Given this list of marker genes BMPR2, GMPPB, CBFA2T3, APP, DHDDS, IHH, ENPP7 (NCBI Gene Id 339221), NME5, AMDHD2, NDUFA3, PTGDR, PIGT, FIGNL1, ATP5PO, HS3ST1, ALG11, AICDA, NDUFC1 (NADH:ubiquinone oxidoreductase subunit C1), EDEM1, ABCC9, MAN2A2, GM2A, ATP5MC3, SYVN1, GAL3ST3, CHPF, MGAT5 (alpha-1,6-mannosylglycoprotein 6-beta-N-acetylglucosaminyltransferase), RRM2B, CERK, C1GALT1, SLC39A8, ENTPD4, MAGT1, NDUFA9, B3GALT9, ALG14, FAM3A, DUT, PTHLH, ATP5F1B, MT-ND1, GALNT4 (NCBI Gene Id 8693), B4GALT1, PGM1, GIMAP7, G6PD, NEIL1, B4GALT7, SMPD1, NECAB3 (N-terminal EF-hand calcium binding protein 3), AKR1A1, HK3, AMPD3 (NCBI Gene Id 272), MIR195, FAM20B (NCBI Gene Id 9917), M6PR, POGLUT2, TMEM260, SLC2A6, ADCY8, RPIA, GPAA1, SULT1A3, TK1, HGSNAT, P2RX7, GK5, MAP2K1, PMM1, LDHC, PRPSAP2, NAGA, RPN1, GCKR, LARGE1, ATP5F1E, PIGN, CTNNB1, UPRT, SLC35C1, LDHA, RPEL1, GALK1, RAN (RAN, member RAS oncogene family), MGAT4D, ATP6V1A, ATP5MK, SORD, FUT6, RENBP, VEGFB, GLB1, PAICS, PPP2CA, NDST3, NAGLU, AKR1B10, CD44, MPI (mannose phosphate isomerase), INS, NCOR1, B3GALT1, PDE5A, DAD1, OVGP1, ALG10, GALNT15, OPA1, GALC, CHST1, ATP5PD, ADAMTS7, ST3GAL4 (NCBI Gene Id 80040), XDH, EGF, FN3K, CHP1, ENTPD7, NDUFB4, ATP5PF, ALG6, DCXR, NDUFA2 (NADH:ubiquinone oxidoreductase subunit A2), MIR181B1, ENO3, CMPK2, ABCA7, UPP1, NDUFV1, TRAK2, STT3A, B3GALT4, TMTC4, MIR17, FREY1, ALDH1A1, HS2ST1, RPTOR, PGLS, SLC35A3, PGLYRP2, PRPS1, NT5M, B3GNT4, ITM2C, PRKAA2, GALNT13 (NCBI Gene Id 114805), CHST8 (NCBI Gene Id 64377), RFK, B3GLCT, RRM2, EXTL2, OGT, NUDT9, NME6, CHST7, XYLT2, PIGF, HS3ST4, FUT10, NUDT15, MGAT4C (NCBI Gene Id 25834), CEMIP2, DOLK, TPI1, OGA, POGLUT1, AK1, RNASEH2B, ALG1L2 (NCBI Gene Id 644974), NAGK, XYLT1, ITM2B, MIR127, NDUFS2, PCSK6, FOXK2, ST6GALNAC2, CYTL1, ADCY2, GALNT18, GMDS, TKFC, DNM1L, ADCY9, UMPS, TRIM13, G6PC3, GNPTG, LCT, ACP6, UBE2J1, CDA, MGAT4A, STT3B, PDE2A, STAT3, HIF1A, LYG1, SGSH, ADK, AK3, POMT1, ADAMTS13, IFNG, PIGZ, RPN2, PGK2, PIGM, ATP6V1B2, ALG9, NPC1, MYH7, GPC1, TDG, GATA1, SDHA, CTNS, PFKFB4, DCTPP1, NECAB2, DGUOK, PDE7B, GMPPA, TRMT12, AKR1C3, JAK3, ENO2, IL4, PCK1, TMEM258, PFKM, MYH6, HAS3, ALG12, PDE8B (NCBI Gene Id 8622), MIR675, HS3ST6, OST4, ABCC6, ITPA, CMAHP, B3GALNT1, FUT9, DHFR2, DTYMK, ENTPD1, NME9, COLGALT1, AMPD2 (NCBI Gene Id 271), ATP5F1D, ZBTB20, NDUFS4, PARG, FBXO2, NFKB1, PGK1, PARP1, MTCH2, LARGE2, GUCY1A1, NPPB, TNFAIP6, GALNT14, CDADC1, GPD1L, MAPDA, PIGA, ALG10B, VCP, RAB23, VPS9D1, ATP1B1 (ATPase Na+/K+ transporting subunit beta 1), FUCA1, UPB1 (NCBI Gene Id 51733), TYW5, CHIT1, CWH43, UXS1, MIR144, PAPSS2, EXT1, GIT1, MGAT3, NDUFB9, HS3ST5, CCR7, ADA, APOBEC3C, AKR1C2, ERP44, UGT8, GUCY1A2, PGM3, CMAS (NCBI Gene Id 55907), ITGB8, CHST12, GALNT5, PAWR, LETMD1, ADSS1, MIR101-1, PGAM1, DSE, HK2, RFT1, PKLR, NEU1, SMPD3, GCNT3, IL33, ATP5MJ, SULT1B1, PDGFB, PGLYRP4, ST3GAL1, MGAT1, CCDC134, XXYLT1, ST3GAL5 (NCBI Gene Id 8869), NUDT4B, GK, FUT7, FPGT, NDST2, PIGH, SULT1E1, DCTD, TGFB1, DHODH, TYMS, AK5, NUDT3, SLC25A13, PLOD3, JMJD8, RRM1, HK1, EXT2, NCCRP1, B4GAT1, PFAS (phosphoribosylformylglycinamidine synthase), RAB1B, GSK3A, PPARA, TGDS, MPDU1, NDST1, OGG1, ADCY6, CHST11, G6PC1, ARNT (NCBI Gene Id 405), EXTL1, ITIH3, TP53, TBPL1, CHST4, NPPA, HDAC4, PIGU, B3GAT2, PMM2, B3GNT9, B3GNT8, MYH3, FBXO6, MIR106A, UGDH, MFSD8, BEND3, PTH, ATP6V1B1, ATP7A, POMK, FUCA2, GK2, HYAL3, MT-ND6, PID1, SLC4A4, KAT2B, PDE4C, MIR147A, GLA, MIR31, SLC51B, ATP5MGL, GALT, CEMIP, PDE10A, PDE1A, ST8SIA6, HYAL1 (hyaluronidase 1, NCBI Gene Id 3373), GPAT3, TNIP1, NCSTN (nicastrin), GNPTAB, NDUFV2, ABCA2, FOXC1, DLG1, EDNRA, MIR644A, MTHFD1, CMPK1, GORASP1, COX11, B3GNT6, NTHL1, NME2P1, CELA1, ATP5F1C, DPY19L3, DPAGT1, GALNT12, RXYLT1, TIGAR, MIR323A, PIGV, PRKAG1, ATP5MG, ATP5IF1, NT5C1B, SLC2A10, HKDC1, BACE2, PRTFDC1, B3GAT3, POGLUT3, RHOQ, HPSE, SMUG1, GMPS, BPGM, PRPSAP1, CLPX, ICMT, B4GALT6, TET2, SLC4A1, SULT1A1, MAN2A1, NDUFC2, TREM2, CHST10, MOGS, UAP1L1, NDUFB2, NDUFA12, LCMT2, RPE, CHST14, FOXL1, PNP, MTAP (methylthioadenosine phosphorylase), SDHC, AATF, SULF2, GANAB, PRKCSH, GCNT7, MLXIPL, GTPBP1 (GTP binding protein 1), TCF7L2, MLST8, HEXB, ST8SIA3, B3GNT5, AKR1C1, ADCY1, PRKACA, ADCY4, IL1B, CASK, BTK, ABHD14B, APCS, GALNTL6, GALNT8, NDUFA7, COL11A1, ADCY5, TYMP, ALG2, LYVE1, TMTC2, FCSK, H6PD, PKM, PRKCD, OSTC, PIGY (phosphatidylinositol glycan anchor biosynthesis class Y), ALG13 (NCBI Gene Id 79868), HTR2A, CHSY1 (NCBI Gene Id 22856), GCNT1, MAGI3, NUDT18, GNPNAT1, UQCC3, UGGT1, FUOM, SHMT1, PTX3, NANS, CARD11, A3GALT2, FBP2, IMPDH2, ENGASE, ST8SIA5 (ST8 alpha-N-acetyl-neuraminide alpha-2,8-sialyltransferase 5), PGAP2, GCNT2 (NCBI Gene Id 880), ANGPT1, NDUFS5, ARFGEF1, NPR1, MT-ND4, TET3, TYW1B, EP300, CREM, SPAM1, MYH4, UCKL1, EFL1 (NCBI Gene Id 79631), PGD, CACNB4, CBR4, GBGT1, ADCY3, MGAT4B, IDS, TRAK1, RORA, GALM, ST6GALNAC1, GPAT2, GALNT16, GBA3, EIF6, CHI3L1, DERA, PGAP1, TET1, ST6GALNAC5, NDUFA1, TYW1, VANGL2, TALDO1, MAN1A2, PXYLP1, ARL2, CRPPA, KRTCAP2, HMMR, AK2, NADK, FBXO27, TMSB4X, HAS1, SULT1A4, NT5C3A, MT-ND3, CHST13, ATP5MC1, QNG1, CANT1, PIGB, SLC35C2, NDST4, MIR298, PIGG, UGCG, POFUT2, B3GALT2, GUCY2F, BMPR1B, NUDT14 (nudix hydrolase 14), ALG5, DHTKD1, PGLYRP3, PIGL, AQP11, ATP5F1EP2, NME3, NUDT10, NDUFB11, NDUFA6, NGLY1, PAPSS1, GALNT7, GLYCTK, NME7, HSPA8, ABO, B3GALNT2, BMP2, ENO4, OGDH, TSPO, ADPGK, ST3GAL6, GALNT2, SPHK2 (NCBI Gene Id 56848), PIGP, A4GNT, GALNT3, ITIH5, TMTC1, MT-ATP6, PFKP, COL2A1, PFKL, PGLYRP1 (peptidoglycan recognition protein 1), ADSL, FOXK1, ENPP1 (NCBI Gene Id 5167), TYW3, GUCY2D, DMAC2L, RAB1A, MAN1B1 (mannosidase alpha class 1B member 1), SLC35D2, AGA, GALE, GXYLT1 (NCBI Gene Id 338841), IER3, B3GAT1, NDUFA8 (NADH:ubiquinone oxidoreductase subunit A8), FUT3, ATP1A2, ADAMTS4, SUMF1, PGAP4, PGAP3, ATP5ME, ENO1, NUDT1 (nudix hydrolase 1), ITM2A, NDUFB10, CLTC, ALDOB, B3GNT3, CHSY3, DPYS, GAPDH, MT-ND5, NDUFS1 (NCBI Gene Id 55372), B3GALT6, G6PC2, DLG2, MACROD2, UGP2, FUT2, RBKS, PDE8A, GMPR2, AKR1C4, NMNAT1, POMGNT1, PRKAG3, DPM3, TAFAZZIN, SLC30A5, CNMD, DPM2, PPARD, PDE7A, HS3ST3A1, LIPA, CHST5, AMPD1, TJP2, NAGPA, DERL3, LEP, ITIH2, PFKFB1, GAL3ST4, NDUFA10, XYLB, MANBA, MPP1, ST8SIA1, ATP5MF, UNG, HSPA1A, GALNT6, PIGK, ZBTB7A, MIR16-1, PRKN, PRKAA1, IMPDH1, GAL3ST1, CSGALNACT1, ABCC5, COG3, BCL2L13, FUT4, C1GALT1C1, PIGX, CTPS1, GFPT1, GALNT9, NDUFB6, GUK1, ALG1, NDUFAB1, SLC35A1 (NCBI Gene Id 10559), RAMP1, GOLGA2, MT-ND2, GXYLT2, NUDT2, NUDT5, PGM2, ST6GAL2, PFKFB3, MIR153-1, PIGO, PGAM4, TMTC3 (NCBI Gene Id 160418), RNF139, GPD1, GCNT4, CRYL1 (NCBI Gene Id 51084), AKR1B1, CHI3L2, GAL3ST2, UST, NPPC, ACOT8, ATIC, CST3, AMFR, NDUFS3, GALNT11, MAN1C1, SRC, MUSTN1, MACROD1, NUS1, EXTL3, TRIP11, PRPS1L1, ST6GALNAC6, TM9SF2, POMT2, B4GALNT2, FKRP, HEXA, EDNRB, PRPS2, ABHD6, MIR20A, GPD2, SDHD, NECAB1, GUSB, FUT11, ITIH6, MFN1 (mitofusin 1), B3GNT2, COG7, OLA1, B4GALT3, NME4, ENPP4, DPY19L1, CAD, CTBS, FLCN, PLOD2, FIS1, CCL21, FUT1, SLC35B2, SIRT6 (NCBI Gene Id 51548), NEU4, PDE4A, CHST9, CHST2, NDUFS7, SLC34A1, ACTN3, HS6ST2, GFPT2, NT5C2, MAN1A1, NME2, AKR7A2, GAPDHS, GUCY1B1, NUDT11, ADA2, ADSS2, SULT2B1, HS3ST2, MT-ND4L, GALNT10, SDHB (NCBI Gene Id 96200), SULT1C4, FUT8, STOML2, FKTN, GLCE, FBXO44, PDE4D, ATP5F1A, POMGNT2, SLC2A4, MT-ATP8, SAMHD1, NDUFS8, PLCB1, TKT, EDEM2, C20orf173, MARCHF6, CHST6, DCK, ADCY7, UCK2, NEU2 (NCBI Gene Id 4759), OARD1, SHPK, DDIT4, ALDOC, TMEM106A, GNS, GFUS, PGAM2, NANP, ST6GALNAC4, FA2H, GBA2, COL6A1, ATP5MC2, A4GALT, BAD, NPL, ITIH1, HS6ST1, GNMT, NT5E, ATP5PB, NDUFA11, HS6ST3 (NCBI Gene Id 283476), GNPDA1, GBA1, HINT1, MTOR (mechanistic target of rapamycin kinase), ENTPD5, PORCN, LMF1, PIGS, TK2, SOAT1 (sterol O-acyltransferase 1), GPI, PPAT, UAP1, GCK, SERP1, DNAJC30, PNLIPRP2, NDUFA5, ST8SIA2, ERH, NDUFA13, RNF5, GUCY2C, B3GNT7, ALDOA, BPNT1, INSR, SCCPDH, BCL2, TMEM165, CLN6, DDOST, NME1, GALNTL5, EPHA2, ATP6V0C, TRIM63, HPRT1, ALG3 (NCBI Gene Id 131416), HYAL2, UCP2, GOLPH3, ST3GAL3, ST6GALNAC3, HYAL4, FBP1, MIR455, ATPSCKMT, MYH8, IDUA, SULT1C3, HS3ST3B1, PDE4B, GNE, ANTKMT, AP2A1, FGF2, SELENON, PRXL2C, PIGW, DNPH1, ITIH4, PINK1, KIT, NUDT4, SRD5A3, ACP3, CHST3, NDUFB7, SULF1, GALNT17, FBXO17, PDE9A, AOAH, NT5C, MPPE1, DPYD (NCBI Gene Id 1806), ACER2, UPP2, IGF1, NDUFB5, EOGT, NDUFV3, LRGUK, SULT1A2, PRKAG2, PIGC, CTPS2, CHIA, DPM1 (dolichyl-phosphate mannosyltransferase subunit 1, catalytic), HAS2, UGGT2, SLC25A10, NUPR1, PLOD1, ST6GAL1, NUDT16, TUSC3, MBD4, SLC10A7, UCK1, APOBEC3G, CCL19, NDUFS6, NEIL2, FUT5, UCHL1, NFE2L1, B4GALT5, NT5C1A, SULT2A1, LYG2, B4GALNT1, RNF103, BLOC1S6, GART, AK9, BAX, RNF185, TPST2, GNAI3, NEU3, NPR2, NDUFB8, ST3GAL2, GNPDA2, TPST1, PIGQ, ADCY10, B4GALT2, SLC25A25, AGO2, CHPF2, MMP12 (NCBI Gene Id 4321), HSPA1B, B3GALT5, NDUFB1, PSEN1, EDEM3, MAN2B1, OGDHL, GALNT1, ST8SIA4, DSEL, ENPP3, POFUT1, GANC, B4GALT4, ADAMTS12, DOLPP1, CSGALNACT2, MGAT2, PFKFB2, APRT (adenine phosphoribosyltransferase), STAB2, ALG8, NDUFB3, CTSL, GDA, ACACB, LRRK2, MIR520C, AK4, TREX1, TMEM59, SCARB2, MGAT5B, here is a description of the gene set: studied in species Homo sapiens The chemical reactions and pathways involving carbohydrate derivative. Human Gene Set: GOBP_CARBOHYDRATE_DERIVATIVE_METABOLIC_PROCESS